The following is a description of a gene set: A renal system process in which albumin is taken up from the collecting ducts, glomerulus and proximal and distal loops of the nephron. Human Gene Set: GOBP_RENAL_ALBUMIN_ABSORPTION studied in species Homo sapiens, and this is the list of marker genes: CD2AP (CD2 associated protein), EDNRB, ADIPOQ, EDNRA, COMT, GAS6